Given this list of marker genes Ccl17, Bcl10, Clec2d, Cxcr2, Clec2h (C-type lectin domain family 2, member h), Tnfrsf4, Il33, Rab23, Ccr2, Pnliprp2, Lat, Ncf1, Ptk2b, B2m, Sh2d1a, here is a description of the gene set: Mouse Gene Set: GOBP_CELLULAR_DEFENSE_RESPONSE A defense response that is mediated by cells. studied in species Mus musculus